The following is a description of a gene set: species: Mus musculus Mouse Gene Set: GOBP_LOBAR_BRONCHUS_DEVELOPMENT The biological process whose specific outcome is the progression of a lobar bronchus from an initial condition to its mature state. This process begins with the formation of the lobar bronchus and ends with the mature structure. The lobar bronchus is the major airway within the respiratory tree that starts by division of the principal bronchi on both sides and ends at the point of its own subdivision into tertiary or segmental bronchi., and this is the list of marker genes: Spdef, Agr2, Wnt7b, Hoxa5, Foxp1, Adamtsl2, Foxp4